Given this list of marker genes STUB1 (STIP1 homology and U-box containing protein 1), UBA5, DEPDC5, IDH1 (NCBI Gene Id 3417), GRM6, ALG13, DAB1, PEX16, IARS2, PRRT2, BRAT1 (BRCA1 associated ATM activator 1), CHD8, RBL2, ZNF408, COL18A1, IQSEC2, ATP1A2, LMNB1, PSAP, EXOSC5, NEDD4L, CNGB3, TTBK2, LARGE1, NDUFS2, SPTBN4, SPTBN2, POLR3B, MAB21L1, GCH1, NR4A2, ALDH18A1, ALX4, TBC1D24, MT-ATP6, OPA1, TPP1, DNM1L, ANO10, HARS1, SCN1A, NSUN2, XRCC1, SACS, ITPR1, PET100, IMPDH2, KCNH1, FGF14, COX15, GMPPA, MRE11, AIFM1, TRAPPC6B, PIGL, ATG5, KIF5A, GPR143, HPS4, FRMD7, SIX6, SLC18A3, SYT14, AP3B1, HPS6, CACNA1A, TMEM126A (transmembrane protein 126A), PAX7, PLP1, GATA3, COQ5, TMEM106B, GRM1, LYST, ERLIN2, KCND3, MARS2, NMNAT1, PEX5, NDUFAF2, GRIK2, THG1L, KCNV2, ARHGEF2, NUP54, FA2H, DPP6, TTR, ATP13A2, MPV17, GRID2, CACNA1G, SURF1, SOX3, BLOC1S3 (biogenesis of lysosomal organelles complex 1 subunit 3), TAF2, GBA1, KIF1C, HMX1, BEAN1, HPS3, SNIP1, NUP62, UROC1, EXOSC9, NFIX, CWF19L1, HPS5, PDGFRB (NCBI Gene Id 5159), MRPL12, SLC35B2, ADAR, ASH1L, LRP5, SUPT16H, here is a description of the gene set: Human Gene Set: HP_HORIZONTAL_NYSTAGMUS Nystagmus consisting of horizontal to-and-fro eye movements. Horizontal nystagmus studied in species Homo sapiens